The following is a description of a gene set: Tumor microenvironment in carcinomas recruits mesenchymal cells with an abnormal proangiogenic and invasive phenotype. It is not clear whether mesenchymal tumor cells (MTCs) derive from the activation of mature fibroblasts or from their stem cell precursors. However, stromal cell activation in tumors resembles in several aspects the mesenchymal rearrangement which normally occurs during reparative processes such as wound healing. Mesenchymal stem cells (MSCs) play a crucial role in developmental and reparative processes and have extraordinary proangiogenic potential, on the basis of which they are thought to show great promise for the treatment of ischemic disorders. Here, we show that MTCs have proangiogenic potential and that they share the transcriptional expression of the best-known proangiogenic factors with MSCs. We also found that MTCs and MSCs have the same molecular signature for stemness-related genes, and that when co-implanted with cancer cells in syngeneic animals MSCs determine early tumor appearance, probably by favoring the angiogenic switch. Our data (1) reveal crucial aspects of the proangiogenic phenotype of MTCs, (2) strongly suggest their stem origin and (3) signal the risk of therapeutic use of MSCs in tumor-promoting conditions. from publication Galiè M, Konstantinidou G, Peroni D, Scambi I, Marchini C, Lisi V, Krampera M, Magnani P, Merigo F, Montani M, Boschi F, Marzola P, Orrù R, Farace P, Sbarbati A, Amici A (PMID 17998939) Stemness-related genes changed in A17 carcinomas (MTC, mesenchymal tumor cells) compared with the mesenchymal stem cells (MSC). species: Mus musculus Human Gene Set: GALIE_TUMOR_STEMNESS_GENES, and this is the list of marker genes: PTCH1, TGFBR2, TNC, PDGFRA, KRT14, BMP4 (NCBI Gene Id 652, bone morphogenetic protein 4)